Given this list of marker genes Cyp7b1 (NCBI Gene Id 99900), Soat2, Pglyrp2, Vwce, Slc17a3, Dio1, Ttc39c, Nudt7, Il1rap, Serpinf1, Lifr, Cldn2, Sc5d, F13b, Hao1, Mbl2, Aadac, Cfi, Acp5, Bdh1, Proz, Asgr1, Cyp2c23, Shld2, Slc22a30, Pnpla7, Alas2, Otc (ornithine transcarbamylase), Ces1e, Nr1i3, Gjb2, C8a, Mfsd2a, Cyp2a12, Sult2a8, Hebp1, Ces2c, Zfand4, Apoc2, Hsd3b5, Kcnn2, Cldn1, Adh4, Mbl1, Tmc7, Mup3, Arhgap9, Pdzk1, Perp, Smlr1, Aspdh, Sdr9c7, Aldh8a1, Qprt, Cyp2c37, Aadat, Cyp2c70, Tfpi2, Enho, Rarres2 (NCBI Gene Id 71660), Hsd3b3, Ugt3a2, Xylb (xylulokinase homolog (H. influenzae)), Keg1, Cfhr1, Mttp, Pcyt2, Adra1b, Cyp2d9, Spata2l, Serpina12 (serine (or cysteine) peptidase inhibitor, clade A (alpha-1 antiproteinase, antitrypsin), member 12), Cyp2d10, Tfr2, F11, Slc45a3 (solute carrier family 45, member 3, NCBI Gene Id 98605), Nlrp6, Cyp2d13, Aqp8, Pxdc1, Masp1, Cideb, Slc30a10, Spp2, Ugt2a3, Ces3b, Serpina1b, Nox4, Entpd8, Cyp4v3, Apoa4, Abat, Hykk, Sucnr1, Sardh, Gcgr, Slco1a1, Slc27a5, Nat8f5, Ly6g2, Gchfr (NCBI Gene Id 320415), Sult1b1, 0610005C13Rik, Hsd3b7, Abcc6, Enpp3, Ces2a, Erbb3 (NCBI Gene Id 97627), Tpmt, Mup1, Ugt2b1, Agmat, Slc22a7, C4bp, Slc23a1, Hsd17b2, Serpina4-ps1, Fabp2, Srd5a1 (NCBI Gene Id 78925), Ceacam1, Cmah, Nlrp12, Hrg, Cpn2, Serpina3m, Acsm1, Glyat, Ugt3a1, Shmt2, Mug-ps1, Cyp8b1, Apon, Tnfaip8l1, Them7, Egfr, Timd2, Slco2b1, Tkfc, Ethe1, C9, Rdh16f2, Rdh5 (NCBI Gene Id 19682), B3galt1, Kyat1, Iyd, Mfsd4b1, Cyp2f2, Inhca, Tlcd2, Ctsh, C6, C8b, Kmo, Fitm1, Cyp2u1, Mfsd4b2, Gm20319, Bbox1, Cyp2c54 (NCBI Gene Id 639023), Mug1, Serpina1a, Mcm10, C8g, Degs1l, Elovl3, Ddc, Apom, Prkd3, Baat, Slc47a1, Mup9, Pla2g12b, Prodh2, Cyp2c50, Ccl9, Insc, S100a10, Faah, Slc3a1, Ces2e, Fam107b, Rarres1, Tmem30b, Mpdz, Cyp2d26, Haao, Lipc, Aqp11 (NCBI Gene Id 66333), Saa4, Car5a, Serpina3k, Cyp4a12a, Wfdc21, F12, Mup5, Ugt2b38, Hsd3b2, here is a description of the gene set: Type 1 iodothyronine deiodinase (Dio1), a selenoenzyme catalyzing the bioactivation of thyroid hormone, is highly expressed in the liver. Dio1 mRNA and enzyme activity levels are markedly reduced in the livers of hepatocyte nuclear factor 4alpha (HNF4alpha)-null mice, thus accounting for its liver-specific expression. Consistent with this deficiency, serum T4 and rT3 concentrations are elevated in these mice compared with those in HNF4alpha-floxed control littermates; however, serum T3 levels are unchanged. Promoter analysis of the mouse Dio1 gene demonstrated that HNF4alpha plays a key role in the transactivation of the mouse Dio1 gene. Deletion and substitution mutation analyses demonstrated that a proximal HNF4alpha site (direct repeat 1; HNF4alpha-RE) is crucial for transactivation of the mouse Dio1 gene by HNF4alpha. Mouse Dio1 is also stimulated by thyroid hormone signaling, but a direct role for thyroid hormone receptor action has not been reported. We also showed that thyroid hormone-inducible Krüppel-like factor 9 (KLF9) stimulates the mouse Dio1 promoter very efficiently through two CACCC sequences that are located on either side of HNF4alpha-RE. Furthermore, KLF9 functions together with HNF4alpha and GATA4 to synergistically activate the mouse Dio1 promoter, suggesting that Dio1 is regulated by thyroid hormone in the mouse through an indirect mechanism requiring prior KLF9 induction. In addition, we showed that physical interactions between the C-terminal zinc finger domain (Cf) of GATA4 and activation function 2 of HNF4alpha and between the basic domain adjacent to Cf of GATA4 and a C-terminal domain of KLF9 are both required for this synergistic response. Taken together, these results suggest that HNF4alpha regulates thyroid hormone homeostasis through transcriptional regulation of the mouse Dio1 gene with GATA4 and KLF9. Genes down-regulated in liver samples of liver-specific knockout of HNF4A. from publication Ohguchi H, Tanaka T, Uchida A, Magoori K, Kudo H, Kim I, Daigo K, Sakakibara I, Okamura M, Harigae H, Sasaki T, Osborne TF, Gonzalez FJ, Hamakubo T, Kodama T, Sakai J (PMID 18426912) species: Mus musculus Mouse Gene Set: OHGUCHI_LIVER_HNF4A_TARGETS_DN